Given this list of marker genes AWAT2, OPN1LW, DHRS3, OPN1MW, OPN1SW, RLBP1, RBP3, here is a description of the gene set: The retinoid cycle in cones (daylight vision) Human Gene Set: REACTOME_THE_RETINOID_CYCLE_IN_CONES_DAYLIGHT_VISION studied in species Homo sapiens